Given this list of marker genes NOP10, METTL4, DKC1, MEPCE, NHP2, LARP7, METTL16 (NCBI Gene Id 79066), here is a description of the gene set: Human Gene Set: GOBP_SNRNA_MODIFICATION The covalent alteration of one or more nucleotides within snRNA, resulting in a change in the properties of the snRNA. studied in species Homo sapiens